The following is a description of a gene set: Mouse Organogenesis Cell Atlas (MOCA) DE_gene_main_cluster.csv, fold.change>=1.5, qval<0.05, pval<0.05 from publication Cao J, Spielmann M, Qiu X, Huang X, Ibrahim DM, Hill AJ, Zhang F, Mundlos S, Christiansen L, Steemers FJ, Trapnell C, Shendure J (PMID 30787437) species: Mus musculus Mouse Gene Set: DESCARTES_ORGANOGENESIS_INHIBITORY_NEURON_PROGENITORS, and this is the list of marker genes: Skor2, Lhx1, Skor1, Slc37a1, Gata3, Fbxl15, 1700001D01Rik, Pax2, Lhx1os, Pax8, Hoxb8, Lamp5, Hoxb2, Otp, Gm13415, Pnoc, Cacna2d3, Hoxb5, Gm16010, 1700025G04Rik, Gm13377, Hoxb9, Gata3un, Rpp25, Asic1, Lhx5, Asic4, Fbxo44, Sec14l5, Selenok-ps1, Klhl14, Scrt1, Lhx5as1, Sox14, Slc6a5, Slc30a3, Lbx1